The following is a description of a gene set: A protein complex containing at least HFE and a transferrin receptor (either TFR1/TFRC or TFR2), proposed to play a role in the sensing of transferrin-bound Fe (Fe2-Tf) on the plasma membrane to regulate hepcidin transcription. Human Gene Set: GOCC_HFE_TRANSFERRIN_RECEPTOR_COMPLEX studied in species Homo sapiens, and this is the list of marker genes: TFRC, BMPR1A, HFE, TFR2, BMPR1B (bone morphogenetic protein receptor type 1B), TF, B2M (beta-2-microglobulin), HJV